Given this list of marker genes LIX1, ST6GAL2, PLP2 (NCBI Gene Id 5355), FAIM2, PDE2A (phosphodiesterase 2A), TNFRSF21, RAPGEF4, HDAC9, LINC01089, TCEAL2, GUCY1A1, CDH8 (cadherin 8), ASPHD1, ISOC1 (isochorismatase domain containing 1), IFI16, NPY2R, PKIA, RUNDC3B, NLGN4Y, RIIAD1, MYT1L, PCLO, KCNQ5, SYT5, CNTN5, SLC17A5, CHRM2, SMAD9, SATB2, ROBO1, CHODL, CNGB1, ZNF804A, LIN7B, GRK3, HEATR5A, PROM1, CHRM3, ERVK3-1, NOL3, GPR27, PCDH10, MTUS1, CPNE8, F12, ADM, VIP, DIPK1A, NPB, CHRFAM7A, YPEL4, CASC15, KCNIP4, NFIC, ACTL6B, AK1 (NCBI Gene Id 203), WFIKKN2, PLPPR2, TMEM255A, GNAO1, SNAP91, LDB2, ATP6V1G2, SLC10A4, DUSP23, LGALS3BP, ARPP21, PTPRR, GCHFR, PCBP3, TCF7L2, TLE2, MAP7, ARFGEF3, FBP1, HTR3A, SYT4, DLX3, PALMD, NEGR1, SGIP1, RNASE1 (NCBI Gene Id 6035), RGS11, MANSC1, CNTNAP2, DMTN, KCNS3, ATP2B4, KIF26B, TRIM67, TTC9B, LINC00623, KIF5A, TAPT1, ARHGDIG, PTPRN, TSPAN7, DNER, CAMK1D, PIRT, NWD2, DPF3, HMX2, PIANP, PLXNA2, C1orf216, FBXL2, SYT17, PCP4 (NCBI Gene Id 5121), GABRG2, UNC5C, LINC01315, DRAXIN, here is a description of the gene set: Human Gene Set: HE_LIM_SUN_FETAL_LUNG_C7_KCNIP4_POS_NEURON_CELL KCNIP4+ neuron species: Homo sapiens from publication He P, Lim K, Sun D, Pett JP, Jeng Q, Polanski K, Dong Z, Bolt L, Richardson L, Mamanova L, Dabrowska M, Wilbrey-Clark A, Madissoon E, Tuong ZK, Dann E, Suo C, Goh I, Yoshida M, Nikolić MZ, Janes SM, He X, Barker RA, Teichmann SA, Marioni JC, Meyer KB, Rawlins EL (PMID 36493756)